The following is a description of a gene set: Human Gene Set: MIR520B_3P_MIR520C_3P_MIR520E_3P species: Homo sapiens from publication Chen Y, Wang X (PMID 31504780) Genes predicted to be targets of miRBase v22 microRNA hsa-miR-520b-3p, hsa-miR-520c-3p, hsa-miR-520e-3p in miRDB v6.0 with MirTarget v4 prediction scores > 80 (high confidence targets)., and this is the list of marker genes: GUCY1A1, ITGB8, ERCC4, TBC1D8B (NCBI Gene Id 54885), PPP6C, SYDE1, ADAM9, CUX2, MAP3K14, MIER3, REEP3, PSD3, PAF1, LYST (lysosomal trafficking regulator), MPC1, MTUS1, TET1, ZNRF3, ZRANB1, DUSP2, RORA, SMARCC2, CREBRF, SLC15A2, MYLK, AAK1, EPHA5, TNFAIP1, UBE2J1, UBE2B, KIF3B, HOOK3, TAPT1, TMEM64, ST3GAL1, LMO3, RSF1, MAN1A1, OLFM3, DRD1, CYP26B1, ZKSCAN1, PHACTR4, NFIB, FRMD4A, CELF2, ASF1B, LAMP5, GLIS3, RPS6KA3, TRAPPC14, CPEB1, CAPRIN2, CCSAP, ARL4C, CLIP4, ST7L, TBC1D2, PTPN21, SUV39H1, VDR, CDC23, NFIA, SKIDA1, RBBP9, FNDC3A, MCL1, BARX2, RAB11FIP5, KAT2B, PHKA1, E2F2, SYTL4, CUX1, SNRK, RGMB, PFKP, ARMC8, LHX6, BLCAP, NUFIP2, PDIK1L, BTG1, MAP3K2, NR2C2, RTN1, FAM168B, ARHGEF17, TSEN34, MARCHF5, RELL1, SSX2IP, TRIP11, PTPRD, CDCA7, MARCHF11, SLC16A10, RABGAP1, MED12L, RAD18, TNKS2, IRF2BP2, UBE2Q2, GRM5, PRDM4, ELK4, SPOP, TANC1, SERF1B, ZNF800, IRF2, CYB5D2, TMUB2, PIGM, TAGAP, INO80D, DDHD1, PKD2, ABHD3, TET3, ZFX, RYR2, DPYSL5, PAK2, FMR1, COG5, MTF1, CFL2, RBL1, R3HDM1, ARID5B, LAMA3, UNKL, TSHZ3, ZNF367, DCUN1D1, SLC24A2, RNF216, DPP8, PAK5, GPR6, MSL1, ZBTB5, AMER2, SON (NCBI Gene Id 84155), SPRED1, SUZ12, SETBP1, ITPRIPL2, FZD3, FYCO1, WDR37, TIAM1, TMEM100, RB1CC1, RELA, PRDM8, LHX8, GPM6A, USP24, ZC3H13, DNAJC27 (NCBI Gene Id 51277), C2orf69, ARID4A, TP53INP1, SLC33A1, ROCK2 (NCBI Gene Id 9475), NPAS3, RSBN1, DENND5B, TGFBR2, CORO2B, TRIM36, HIPK3, RGL1, MCC, TXNIP, ASAP1, NHSL3, REST, NR4A3, ASF1A, ALDH1L2, EZH1, EIF3M, LRP8, H2AJ, PHF12, USP46, ANKRD52, RUBCN, ZFYVE26, LCOR, SMNDC1, FAT4, DCAF6 (NCBI Gene Id 55827), LRP2, ZBTB7A, PPARA, RRAGD, SERF1A, PDE8A, DYNC1LI2, ZNF827 (zinc finger protein 827, NCBI Gene Id 152485), RAB11A, ZNF532, GNPDA2, HP1BP3, PRRG1, RUNX2, SNX8, CXCL1, E2F7, TWF1, PDE4D, USP16, GPC6, SLC40A1, RAB22A, SLAIN2 (SLAIN motif family member 2), PARP8, PKHD1, RASGEF1A, ZNF385A, BCAP29, MKNK2, SDC1, FSTL5, MBNL3, MYRF, ZBTB11, BCL6, KPNA2, DNAI7, SPTLC2, PTGDR, SLAIN1, AGO1, ARID4B (NCBI Gene Id 88087), DCUN1D4, PLAG1, FGD5, MICA, CMTR2, LEFTY1, RAB5C, TFAP4, RFX3, RNF6, SS18L1, ARHGEF10, POLQ, EXOC5, HIF1AN, TIPARP, ANKRD17, ZNF362, MFAP5, MBD2, ZBTB41, C6orf15, TMEM123, NFYA (nuclear transcription factor Y subunit alpha), RAB11FIP1, MIGA2, SHCBP1, VLDLR (very low density lipoprotein receptor), GUCA1C, YOD1, JAZF1, RASSF2, TMTC2, ATAD2, GALNT3, FGD4 (NCBI Gene Id 619403), TCAIM, E2F5, CNOT6, KIF26B, HECTD2, PHF14, SUCO, FZD6, GPCPD1, ARHGAP30, TMEM170B (transmembrane protein 170B), LATS2 (NCBI Gene Id 95108), CYP20A1, C2CD2, SRCIN1, TET2, KMT5B, KREMEN1, CCNJ, BCL11A, SAMD12, MYCN, CROT, HDAC4, ELAVL2, CREB5, ATF6B, ISM2, CYBRD1, APP, ADAT2, EDNRB, TNRC18, IKZF2, PLAGL2, GLCE, SYNC, ZBTB33, OXR1, MAPK9, ZNF75A, QRSL1, GDF11, TMEM86A, KDM1B, ANO6, LEFTY2, HAUS8, SLC22A23, CYBB, MIXL1, HS2ST1, UNC80